The following is a description of a gene set: Any process that activates or increases the frequency, rate or extent of kinase activity, the catalysis of the transfer of a phosphate group, usually from ATP, to a substrate molecule. species: Homo sapiens Human Gene Set: GOBP_POSITIVE_REGULATION_OF_KINASE_ACTIVITY, and this is the list of marker genes: CALCA, CLSPN, PIK3R5, MAP3K4, RASSF2, PPIA, TAB2 (NCBI Gene Id 23118), ADCY8, ZFP91, ABI1, FBN1, XRCC6, PTK2B, TCIM, KIF14, TPX2, SRCIN1, FLT3 (NCBI Gene Id 2322), MAP2K1, DRD4, ELANE, PDGFB, ZNF622, MMD2, FGF1, DDR2, ANGPT1, CD4, AGAP2, FGF2, NRG1 (NCBI Gene Id 653104), HMGA2, MAP3K11, STRADB, COPS8, MAP3K5, GPRC5B, TENM1, DIRAS1, TNFRSF10A, ITGB1BP1, PIK3R6, STOX1, CEMIP, DYNAP, LTF, SRC, TRAF4, TRAF6, LEP, EREG, DOK7, TNFSF15, MAP2K2, LAT, EZH2, S100A12, PIH1D1, RALB, ARHGEF5, ADIPOQ, PTK2, ADCYAP1, MAP2K3, TAOK3, LMO4, TNFRSF10B, ERBB2, FGF18, TPD52L1 (TPD52 like 1), PRLR, TNF, MAP4K2, CIMAP3, JAK2, XRCC5, TLR6, TRAF2, PIBF1, PDCD10, EEF1A2, SIRT1, IFNG, ADAM17, UNC119, MST1R, SYAP1 (NCBI Gene Id 94056), MMD (monocyte to macrophage differentiation associated), SNX9, STRADA, LILRA5, ECT2, MT3, CENPE, WNT5A, HLA-DRB1, CSF1R, STK11, ABL1, NEDD9, JTB, RAPGEF2, PDGFRB, PRKCD, SPDYA, RASGRP1, TOM1L1, LCP2, CAB39 (calcium binding protein 39), TIGAR, CARD14, MRNIP, ZNF16, TLR3, CIB1, CD74, DSTYK, PIM1, PTPRC, CHI3L1, IGF1 (insulin like growth factor 1), DIPK2A, FLT1, RHOA, CASS4, RAP1A, CCNY, ERN1, SASH1, GAS6, CAMK1, NEK10, MAP3K7, CACUL1 (NCBI Gene Id 143384), PSMD10, RIPK3, CARD10, CRIPTO, ETAA1 (NCBI Gene Id 54465), IRGM, ALS2, CDKN1A, CCDC88A, MAP3K10, PTPN1, FGFR1, DIRAS2, PILRB (NCBI Gene Id 29990), PIK3CG